The following is a description of a gene set: The process whose specific outcome is the progression of the autonomic nervous system over time, from its formation to the mature structure. The autonomic nervous system is composed of neurons that are not under conscious control, and is comprised of two antagonistic components, the sympathetic and parasympathetic nervous systems. The autonomic nervous system regulates key functions including the activity of the cardiac (heart) muscle, smooth muscles (e.g. of the gut), and glands. Human Gene Set: GOBP_AUTONOMIC_NERVOUS_SYSTEM_DEVELOPMENT studied in species Homo sapiens, and this is the list of marker genes: ADARB1, GATA3, PHOX2A, PRLH, SOX4, VCAM1 (NCBI Gene Id 7412), HOXB2, HLX, KIF26A, GDNF, SOX11, SIX1, SLC6A4, TFAP2B, HOXB1, NRP2, TLX2, RET, TFAP2A, SEMA3A, GBX2, NF1, NAV2, TBX1, SEMA3F, HAND2, INSM1, FN1, TP63, NRP1, NTRK1, PLXNA3, PHOX2B, GFRA3, FZD3, PHACTR4, EDNRB, SOX8, EGR2, HES1 (NCBI Gene Id 3280), ACKR3, CTNNB1 (catenin beta 1), PLXNA4, SOX10, ASCL1, EDNRA